Given this list of marker genes Bcl2l1, Agt, Pitx2, Adam21, Ing2, Tsx, Oas1d, Tnfaip6, Adrm1, Casp3, Tlr9, Spata2, Mamld1, Esr2, Ccno, Bok, Zfx, Sfrp2, Gmnc, Dhh, Mfn2, Ren1 (renin 1 structural), Nup107, Rbmyf7, Atm, Inhbb, Tgfb2, Rbmyf5, Retn, Rbp4, Rab13, Vgf, Nobox, Lhb, Bcl2, Adam20, Rnase10, Klhl10, Zfpm2, Sry, Srd5a2, Icam1, Eif2b4, Adam1b, Wnt4, Acvr2a, Dnaaf11, Gata1, Dmrt1, Lep, Idh1, Nr5a2, Cftr, Wnt5a, Adam6b, Ybx3, Rrm1, Serpinb6a, Dach1, Insl3, Foxc1, Gm17266, Ctsl, Kcne1, Brca2 (breast cancer 2, early onset), Kdr, Stat5b, Cga, Abcb1a, Adam15, Flna, Adam2, Ccnd1, Npr2, Tesc, Ube3a, Scx, Foxo3 (forkhead box O3), Tex19.2 (testis expressed gene 19.2), Casp2, Safb2 (scaffold attachment factor B2), Eif2s2, Adamts1, Nos3, Bcl2l2, Dach2, Dmc1, Lhx8, Ercc1, Kitl, Fshr, Tmf1, Lrp2, Tnfsf10, Gata6, Ahr, Sod1, Nkx3-1, Bik, Zp3, Hoxa11, Eif2s3y, Smad4, Nupr1, Rbmy, Kit, Aspm, Cebpb, Gpr149, Angpt1, Crkl, Adam26a, Wt1, Esr1, Cited2, Lfng, Scaper, Brip1, Sox9, Nefh, Asmt, Nos2 (NCBI Gene Id 18126), Ncoa1, Arrb2, Adam29, Mcidas, Nudt1, Ace, Adgrg1 (NCBI Gene Id 56037), Runx1, Rbmyf9, Taf4, Fance, Umodl1, Fgf8, Mmp14, Hesx1, Adam26b, Wnt2b, Akap9, Nhlh2, Nkx2-1, Cd2ap, Cbx2 (chromobox 2), Lhx9, Hoxa10, Rara, Gas2, Arid5b, Itgav (NCBI Gene Id 76358), Inha, Gnrh1, Sema3a, Nup210l, Sfrp1, Inhba, Jmjd1c, Sohlh1, Eif2b5, Bax, Eif2b2, Arid4a, Hmga2, Myh9, Rxfp2, Adam34l, Il1a, Pla2g4a, Pcyt1b, Ar, Ereg, Notch1, Fanca, Patz1, Tcf21, Fndc3a, Lhfpl2, Rbmyf1, Foxl2, Gm4787, Msh2, Fshb, Slit3, Ccdc182, Rec8, Tex11, Adam3, Adam34, Gfra1, Irx5, Afp, Odad3, Ctnna1, Sohlh2, Tlr3, Edn2, Lhcgr, Msh4, Adam4, Cyp19a1, Dhx37, Cbl, Sdc1, Adam39, Ago4, Wdr19, Mas1, Kif18a, Hyal3, Ptprn, Map7, Tex19.1, Vegfa, Kdm5a, Fst, Sgpl1, Stat5a, Ptger4, Mmp19, Insl6, Ahsg, Rad21l, Fancg, Gja1, Kmt2b, Atn1, Fgf7, Six4, Gata4, A2m, Plekha1, Gata3, Arid4b, Hoxa9 (homeobox A9), Sprr2d (NCBI Gene Id 20758), Serpine1, Arrb1, Lsm14b, Ermp1, Adcyap1, Immp2l, Adam18, Tiparp, Six3, Zfp830, Csmd1, Grk2, Fzd4 (frizzled class receptor 4), Bmp4, Amh, Rbmyf8, Rhobtb3, Spink2, Dmrta1, Bcl2l11, Adam25, Nanog, Fgf9, 2610005L07Rik, Adam1a, Atrx, Gdf9, Nrip1 (nuclear receptor interacting protein 1), Tbc1d20, Sf1, Ntrk1, Sox8, Sox3, Wdr48, Nr5a1, Rbmyf6, Prdx4, Rbmyf3, Pdgfra, Adam24, Src, Fer (FER tyrosine kinase), Star, Ptx3, Rbmyf2, Hsd17b4, H3f3b, Rdh10, Pgr, Cyp1b1, Mmp2, Tgfbr1, Bmpr1b, Adam32, Spo11, Osr1, Sirt1, Hnrnpk, Hmgb2, Dnaaf3, Adam30, Adam6a, Bcas2, Nr0b1, Schip1, Adam5, Fancf, Amhr2, Pde4d, Insr, Phb1, Nr2f2, Nppc, Ubb, Rac1, Tfpt, here is a description of the gene set: Mouse Gene Set: GOBP_DEVELOPMENT_OF_PRIMARY_SEXUAL_CHARACTERISTICS The process whose specific outcome is the progression of the primary sexual characteristics over time, from their formation to the mature structures. The primary sexual characteristics are the testes in males and the ovaries in females and they develop in response to sex hormone secretion. species: Mus musculus